The following is a description of a gene set: Reactome Pathway: Synthesis of PI studied in species Mus musculus This event has been computationally inferred from an event that has been demonstrated in another species.<p>The inference is based on the homology mapping from PANTHER. Briefly, reactions for which all involved PhysicalEntities (in input, output and catalyst) have a mapped orthologue/paralogue (for complexes at least 75% of components must have a mapping) are inferred to the other species. part of: Glycerophospholipid biosynthesis electronically inferred by orthology from the curated human pathway, and this is the list of marker genes: Cds1, Pitpnm3 (PITPNM family member 3), Pitpnm2